The following is a description of a gene set: The morphogenetic process in which the foregut region specified to become the lung forms the initial left and right buds. Mouse Gene Set: GOBP_PRIMARY_LUNG_BUD_FORMATION species: Mus musculus, and this is the list of marker genes: Hhex, Ctnnb1, Wnt2, Wnt2b, Rdh10